Given this list of marker genes Pdia3, Rps27a, Calr, Ubc, Uba52rt, Uba52, Ubb, Canx, here is a description of the gene set: Mouse Gene Set: REACTOME_CALNEXIN_CALRETICULIN_CYCLE Calnexin/calreticulin cycle species: Mus musculus